Given this list of marker genes HSPA4, AARSD1, DYNC1LI2, GPR4, H2BC1, SPAST, CHFR, SUSD3, FLT1, RABAC1, YIPF3, C6orf89, PSMD14, NDUFV3, RRAS, UBQLN1, LASP1NB, UBE2V1, AACS, VPS50, ZSCAN2, TFEB, NR2F2 (nuclear receptor subfamily 2 group F member 2), PLEKHO2, MTHFD1L, TAF6, C6orf47, SLC29A1, FBXL12, YKT6, MFN2, GLE1, DCTN6, COPZ1, NSUN3, NUP188, OXNAD1, STARD4, ATPAF2, SRPK1, MAP4K5, MTG1, ARPIN, RAB3A, USP39, TCTN2, ASNSD1, SRA1, YBX3, PIGP (NCBI Gene Id 53821), MIS12, CKAP2, ARHGAP19, TMEM120A, ATP5MC3, FAM168A, NUP133, NOSTRIN, PLA2G15, SDHAF3, LIPT2, NTAQ1 (NCBI Gene Id 55093), SDHB, TTYH2, VAPB, CDC26, TAF1A, PPP6R2, KDM8, VPS16, ANKRD9, DDX10, RNF103, MRPS21, FBXO46, XPC, PLK1, UBE2G1, CSNK2A1, TSPYL4, SMYD1, PCNX4, ADAM5, TRMU, FANCE, EID1, SRP19, GNG2 (G protein subunit gamma 2), HSP90B1, AP5S1, PDE6D, RPP30, TMEM11, SNORA2C, COA6, PDE4B, RAB1B, FBXL5, AGPAT5, GFPT1, ALDH6A1, ZNF670, RAB24, METTL21A, MOB3A, DAD1, TRAPPC14, HDAC10, PTGES2, CPSF3, POLR2B, ZNF106, FANCA, SCRIB, EIF2A, UHRF1 (NCBI Gene Id 96185), COPS7B, RPP21, TRIM23, HOOK1, CPT2, ZBED3, RARA, MICU3, RNF180, SYNGR2, SLC25A14, PDCD7, UQCC1, ZRANB2, TBXAS1, TPD52, MLF2, DPP8, SRSF2, ICE2 (interactor of little elongation complex ELL subunit 2), PPEF2, BCL7A, CLASP1, GLO1, WDR18, CDC37L1, IPO8, SUFU, TERF2 (NCBI Gene Id 7014), MIS18BP1, STARD5, TCF19, RPF2, PDXP, MIEF2, FBXL20, RPAP2, SNX3, PHF20, FAM234B, PRMT3, ATG9B, LIG4, S100PBP, MAN2A2, PIGX, DBF4, TMX1, ZFAND1, PSMD9, SLC39A7, SLC39A9 (solute carrier family 39 member 9), GM2A, FNTA, PRCC, BID, CNOT6, GALNT2 (polypeptide N-acetylgalactosaminyltransferase 2), NUDT19, ZDHHC7, GCSH, CBY1, IQSEC1, SESN2, RPS6KA2, METTL4, SMARCAL1, SULF2 (NCBI Gene Id 55959), FEM1A, here is a description of the gene set: Pioglitazone treatment of CD4+FoxP3- T cells transduced with Pparg and Foxp3 up-regulated a set of genes whose products have been implicated in lipid metabolism pathways. To verify the specificity of this treatment, we performed microarray analysis on Foxp3+Pparg1-transduced CD4+FoxP3- T cells after treatment with other PPARg agonists such as Rosiglitazone (TZD) and GW1929 (non-TZD). from publication Cipolletta D, Feuerer M, Li A, Kamei N, Lee J, Shoelson SE, Benoist C, Mathis D (PMID 22722857) Human Gene Set: GSE37534_PIOGLITAZONE_VS_ROSIGLITAZONE_TREATED_CD4_TCELL_PPARG1_FOXP3_TRANSDUCED_UP studied in species Homo sapiens Genes up-regulated in CD4 T cells treated with rosiglitazone and over-expressing: FOXP3 and PPARg1 isoform of PPARG versus FOXP3 and PPARg2 isoform of PPARG.